The following is a description of a gene set: Overview of nanoparticle effects species: Homo sapiens Human Gene Set: WP_OVERVIEW_OF_NANOPARTICLE_EFFECTS, and this is the list of marker genes: PTK2, COL4A1 (NCBI Gene Id 1282), HMOX1, IL6, NFRKB, BCL2, LAMA3, TNF, CXCL8, AKT3, PIK3CD, CRP, CCND3, FN1, PTGS2, CDH3, ITGAD, PTGS1, BAX